Given this list of marker genes CENPE, CDCA3, HSD17B11, CCDC34, ANXA2, PRR11 (proline rich 11), CENPA, CDKN3, PLK1, LGALS1, NOTCH2NLA, SMTN, TMEM256, KNSTRN, AURKA, GAS2L3 (growth arrest specific 2 like 3), CKS2, BUB1B, CRYZ, PLIN3, NUSAP1, CDCA8, CENPF, DEPDC1B, SGO2, CCNB2, OIP5, CKAP2, CEP70, TROAP (trophinin associated protein), TUBB6, PSRC1, KIF20A, DCXR, ODF2, RACGAP1, EMP3, SHCBP1, KIF18A, TACC3, CCNA1, RP2, BIRC5, ARL6IP1, TXNDC12, SFRP2, CCNB1, MZT1, ASPM, BUB1, TPX2 (NCBI Gene Id 23477), UNC50, NEK2, PRC1, ITGB1BP1, NMU, CRNDE, TUBA1C, TUBB4B, CDC20, MT2A, PTTG1, here is a description of the gene set: species: Homo sapiens from publication Zhong S, Zhang S, Fan X, Wu Q, Yan L, Dong J, Zhang H, Li L, Sun L, Pan N, Xu X, Tang F, Zhang J, Qiao J, Wang X (PMID 29539641) Human Gene Set: ZHONG_PFC_C8_ORG_PROLIFERATING